Given this list of marker genes RPS15A, GNB1, RNU7-1, ATRX, RPS10, ARHGAP26, SAMD9, NSD1 (nuclear receptor binding SET domain protein 1), PDGFRA, EP300, DNMT3A, SCN11A, RPL18, DNAJC21, RPS24, KRAS, ALAD, EVC, NUP214 (NCBI Gene Id 9680), DKC1, NSUN2, RPS26, DYNC2LI1, FLT3, ATM, ABL1, CHIC2, IDH1, TREM2, ADA2, CHEK2, SCN9A, RPL8, BRD4, LPP, RECQL4, RPL31, MLLT10, ETV6, RNASEH2A, MBD4, RIT1, PIGL, TCIRG1, BRCA2, RRAS, IFIH1, HEATR3, RPL35A, CALR, GATA1, RPS28, SRP19, THPO, TSR2, IKZF1, RPL15, SOS1, RPS19, TYROBP, H4C9, NUTM1, NOP10, PICALM, UBE2T, RPS27, ANAPC1, TREX1, FANCG, CEBPA, GATA2, RPS17, MPL, SPRED2, TAL2, RPL35, ADH5, ERBB3, RRAS2, CBL, PALB2, APC, F13B, EVC2, BLM, RPS29, DDX41, PTPN11, PTPN6, TERT, BRAF, KIT, EFL1, PRKACB, STS, RPS20, ELANE, TAL1, FANCD2, LZTR1 (leucine zipper like post translational regulator 1), CEP57, CLPB, WAS, KIF11, MDM2, NF1, CDKN2A, SMPD1, SAMHD1, FANCA, RB1, LSM11, SCN10A, NRAS, PRKACA, NBN, SH3GL1, SRP54, FANCC, TET2, FANCE, SOS2, RAF1, GLI1, RARA, NPM1, RPL5, ASXL1, TCF3, GFI1, RPL9, SF3B1, ADAR, MLH1, SBDS, SAMD9L, SRSF2, DUT, MRAS, RPL26, BUB1, RNASEH2B, SH2B3, RASA2, BUB3, APC2, RPL27, JAK2, BUB1B, XRCC4, RPS14, LIG4, RUNX1, PIK3R1, RPL11, TP53, RNASEH2C, MEFV, CREBBP, WIPF1, MYD88, TERC, MSH2, TRIP13, RPS7, HAX1, PIK3CA, F13A1, BAX, SPRED1, BCR, SETBP1, MAP2K1, here is a description of the gene set: studied in species Homo sapiens Leukemia Human Gene Set: HP_LEUKEMIA A cancer of the blood and bone marrow characterized by an abnormal proliferation of leukocytes.